Given this list of marker genes Ly6i, Abi3, Lman2, Lgmn, Pdlim4, Mrps18a, Slc35b1, Ly86, Ly6e, Tgfbi, Unc93b1, Nrp1, Vcam1, Vps11, here is a description of the gene set: Cytokines mediate cell-cell communication in the immune system and represent important therapeutic targets. A myriad of studies have highlighted their central role in immune function, yet we lack a global view of the cellular responses of each immune cell type to each cytokine. To address this gap, the authors created the Immune Dictionary, a compendium of single-cell transcriptomic profiles of more than 17 immune cell types in response to each of 86 cytokines (>1,400 cytokine-cell type combinations) in mouse lymph nodes in vivo. A cytokine-centric view of the dictionary revealed that most cytokines induce highly cell-type-specific responses. For example, the inflammatory cytokine interleukin-1β induces distinct gene programmes in almost every cell type. A cell-type-centric view of the dictionary identified more than 66 cytokine-driven cellular polarization states across immune cell types, including previously uncharacterized states such as an interleukin-18-induced polyfunctional natural killer cell state. species: Mus musculus Mouse Gene Set: CUI_CDC2_LEPTIN_RESPONSE_UP Genes positively differentially expressed in cell type: cDC2 (conventional dendritic cell type 2) upon treatment with cytokine: Leptin in mouse lymph nodes in vivo. from publication Cui A, Huang T, Li S, Ma A, Pérez JL, Sander C, Keskin DB, Wu CJ, Fraenkel E, Hacohen N (PMID 38057668)